The following is a description of a gene set: from publication Lake BB, Chen S, Hoshi M, Plongthongkum N, Salamon D, Knoten A, Vijayan A, Venkatesh R, Kim EH, Gao D, Gaut J, Zhang K, Jain S (PMID 31249312) species: Homo sapiens Human Gene Set: LAKE_ADULT_KIDNEY_C21_COLLECTING_DUCT_INTERCALATED_CELLS_TYPE_B, and this is the list of marker genes: FOXO1, NEDD4L, MAGI3, TBC1D4, ESRRG, L3MBTL4, GULP1, SPTLC3, NCOA2, SLC35F3 (solute carrier family 35 member F3), TFCP2L1, BMPR1B (NCBI Gene Id 658), SIK3, SKAP1, COL4A4, ITGA6, PPARG, ADAMTSL1, GPHN, IGFBP5, DACH1, MACROD2, TMEM213, RALGAPA2, IL18, LGR4, ARSJ, KMT2C, TBC1D5, FBXL17, PRKN, ATP6V0A4, ARHGAP18, FAF1, KIF21A, PDE1C, JADE1, PDE4D, SSBP2 (single stranded DNA binding protein 2), ATP6V1H, PLCG2, PRKCE, CGNL1, OSBPL3, SLC4A9, WWOX, FOXP1, TRHDE, PACRG, ADAMTSL3, FREM1, WDR72, UBE2E2, PLCL1, DGKI, TBL1X, GAREM1, MAGI1, MAPK8, LPP, RCAN2, NEBL, MEF2A, PHLDB2, MYRIP, PPARGC1A, GLCCI1, CELF2, FHIT, IQGAP2, PICALM, RNF150, LRMDA, GPC6, MAP3K5, SCIN, SDCCAG8, XIST, SEMA3C (NCBI Gene Id 222200), NCOA7, QKI, SOX6, KIF13B, CLNK, HERC1, RORA, NR3C2, MITF, PARD3B, TMEM117, MSI2, PSD3, PPP3CA, SNTB1, EPS8, CA12, SLC26A4, ARL15, PTPRJ, ATP6V0D2, ZBTB20, CA8, RNF152